Given this list of marker genes Alox5, Hpgd, Ltc4s, Alox5ap, Alox12, here is a description of the gene set: Mouse Gene Set: REACTOME_BIOSYNTHESIS_OF_LIPOXINS_LX studied in species Mus musculus Biosynthesis of Lipoxins (LX)